The following is a description of a gene set: studied in species Homo sapiens Genes down-regulated in Cockayne syndrome fibroblasts rescued by expression of ERCC6 off a plasmid vector. Cockayne syndrome (CS) is an inherited neurodevelopmental disorder with progeroid features. Although the genes responsible for CS have been implicated in a variety of DNA repair- and transcription-related pathways, the nature of the molecular defect in CS remains mysterious. Using expression microarrays and a unique method for comparative expression analysis called L2L, we sought to define this defect in cells lacking a functional CS group B (CSB) protein, the SWI/SNF-like ATPase responsible for most cases of CS. Remarkably, many of the genes regulated by CSB are also affected by inhibitors of histone deacetylase and DNA methylation, as well as by defects in poly(ADP-ribose)-polymerase function and RNA polymerase II elongation. Moreover, consistent with these microarray expression data, CSB-null cells are sensitive to inhibitors of histone deacetylase or poly(ADP-ribose)-polymerase. Our data indicate a general role for CSB protein in maintenance and remodeling of chromatin structure and suggest that CS is a disease of transcriptional deregulation caused by misexpression of growth-suppressive, inflammatory, and proapoptotic pathways. Human Gene Set: NEWMAN_ERCC6_TARGETS_DN from publication Newman JC, Bailey AD, Weiner AM (PMID 16772382), and this is the list of marker genes: PAGE2, PSG9, KCNK2, GALNT5, NEAT1, LRCH2, HAPLN1, PAMR1, CDKN1A, PTGS1, SEPTIN11, SCUBE3, SERPINE1, CCDC80, SPATA18, RAB3B, PODXL (podocalyxin like), SLC1A1, COL11A1, MFAP5, PSG5, RECK, ZMAT3, TAFA5, ITGBL1, AEBP1, SGCD, KRT34, RGS4, LBH, FGF5, CNTN3, GABBR2, CEMIP (cell migration inducing hyaluronidase 1), PSG6, LNX1, NGF, ADAMTS1, SYNPO2